The following is a description of a gene set: studied in species Mus musculus Mouse Gene Set: GOCC_ENDOPLASMIC_RETICULUM The irregular network of unit membranes, visible only by electron microscopy, that occurs in the cytoplasm of many eukaryotic cells. The membranes form a complex meshwork of tubular channels, which are often expanded into slitlike cavities called cisternae. The ER takes two forms, rough (or granular), with ribosomes adhering to the outer surface, and smooth (with no ribosomes attached)., and this is the list of marker genes: Lrit3, Cercam, Sec61bl, Sema4f, Cyp3a41a, Nat8f2, Bfar, Mboat1, Elovl2, Slc30a9, Sec24d, Zdhhc4, Rps29, Hsd3b3, G6pc1, Apbb2, Ddn, Shisa5, Znrf4, Cd1d2, Nr3c2, Hrc, Gdi1, Minpp1, Dse, Tsn, Sqstm1, Gabarapl2, Nhlrc1, Icmt, Cyp3a25, Camk2d, Mgat4d, Atp8a1, Keap1, H2-M10.4, Ugt1a9, Ugt1a7c, Ebpl, Ch25h (cholesterol 25-hydroxylase), Apob (apolipoprotein B), Rps3a1, Mlec, Srd5a1, Arxes2, Mpig6b, Or7a40, P3h3, Cyp2a4, Scd4, Dlc1, H2-M10.3, Eef1g, Gabbr1, Prkcd, Vps13c (vacuolar protein sorting 13C), Il12a, Pigg, Ier3ip1, Tmed6, Creb3l3, Golt1b, Cemip, Hspbp1, Rp9, P4ha3, Creb3, Stard3nl, Abhd12b, Gnai3, Bace2, Pkd2l1, Duox2 (dual oxidase 2), Osbpl6, Pcdha2, Tmem86b, Phtf1, Sumf1, Tmtc3, Apoc1, Rnf133, Pigb, Rpl10, Ano9, Ufl1 (UFM1 specific ligase 1), Rnf148, Rpl34-ps1, Or10j5, Edem2, Plpp2, Prkce, F12, Agr2, App, Slc39a7, Mttp, Ryr1, Ldaf1 (lipid droplet assembly factor 1), Tenm1, Jph2, Lama3, Stx16, Fam8a1, Mogat1, Agpat2, Ugt8a (UDP galactosyltransferase 8A), Stau1, Retreg3, 1600014C10Rik (NCBI Gene Id 72244), Frey1, Ddrgk1, Rtn2, Alg13, Myrfl, Mtmr9, Abcb9, Maco1, Rpl27a (NCBI Gene Id 26451), Ubqln4, Glul, Usp25, Stub1, Pld1, Wfs1, Pja2, Selenon, Col6a1, Cyp3a41b, Sumf2, Pdilt, Ctdnep1, Zc3h12a, Atp8b1, Tm4sf20, Cyp39a1, Lemd2, Itpkb, Hap1, Cyp2c37, Tmem67, Esyt3, Mlc1, Dmtn, Arsa, Acat1, Epha5, Duoxa1, Pcdha4, Emc1, Tmt1a, Tpp2, Apex1, Wnt6, Cerkl, Dpy19l1, Tmem30c, Gm5431, Pip4k2b, Cd3e, Rnf185, Nol3, Clcn4, Dolk, Dsc2, Tmem170, Txndc16, Ube2g2, Ythdc2, Get1, Rnf122, Thbs4, Lrp5, Dio1, Soat2, Pofut2, Lpcat3, Vhl, Rheb, Fibin, Arb2a, Alg3, Rab3gap2, Dhrs7c, Lrrc8d (leucine rich repeat containing 8D), Itpr1, Insig1, Tlcd4, Hsd17b2, Cyb561d2, Yipf4, Or2c1, Asph, Derl3, Ndfip2 (NCBI Gene Id 77152), Ubxn4, Ggt1, Poglut3, Ssr2, Saysd1, Hk2, Bscl2, Alg11, Rab10, Utp15, Mal, Cyp2a5, Stim2, Clic1, Atp2a3, Bcl2l1, Lmbr1l, Sdf4, Gpx7, Steep1, Mgst1, Pigv, Dus2 (NCBI Gene Id 66369), Pomk, Parp6, Ormdl3, Ero1b, Arxes1 (adipocyte-related X-chromosome expressed sequence 1), Vcpip1, C2cd2l, Vapb, H2-M11 (histocompatibility 2, M region locus 11), Rce1, Pcsk9, Tor1b, Serpina1b, Apod, Fitm2, Atg9a, Naxd, Hyou1, Mmp27, Kcnq1, Cyp2d9, Tmc8, Tmem100, Ncstn, Por (cytochrome p450 oxidoreductase), Slc39a1, Sacm1l, Atl3, Vti1a, Uvrag (NCBI Gene Id 78610), Pigyl, Lman2, Dhcr7, Tap1, Mmgt1, Acsl4, Tmem33, Pacs2, Awat1, Degs1, Emc8, Mamdc2, Fkbp1b, Rnf26rt, Rdh16f2, Aqp11, BC016579, Alg9, Cyp4a12a, Rnf103, Gramd1b, Dnase1l1, Pgs1, Tmem199, Cdc14a, Aph1b, Rnf180, Oprm1, Nsdhl, Sdr16c5, Ahcyl1, Ptpn1, Tex2, Fmn2, Tmem120a (NCBI Gene Id 215210), Pgap2, Sec22b, Rnf121, Alg14, Alg10b, Tor4a, Sptlc3 (serine palmitoyltransferase, long chain base subunit 3), Or5b21, Tmem147, Pomgnt2, Duox1, Pomp, Ppib, Sel1l2, Marchf2 (NCBI Gene Id 78665), Pomt2, Usp20, Sort1, Notch1, Rab9, Tlcd3b, H2-Q1, Dipk1c, Elavl1, Grina, Tmem109, Vapa, Rdh10, Agpat3, Rnf125, Plcd4, Ubxn1, Kdelr2, Phex, Colgalt2, Cast, Pex3, Ephb1, Zdhhc18, Atg2b, Pdcl2 (NCBI Gene Id 93801), Tapt1, Nat8b-ps, Brsk2, Tram1, Ptdss2, Cpeb4, Becn1, Slc2a4 (NCBI Gene Id 20528), Yipf5, Creb3l2, Syncrip, Rsad2, Cyp26b1 (NCBI Gene Id 232174), Col26a1, Esyt1, Sec61a2, Pdcl3, Marchf1, Grin2b, Tmem86a, Tenm2, Igll1, Pld4, Nat8f7, Nkiras1, Edem3, Rpe65, Pigs, Usp19, Man1b1, Ccdc78, Vpreb3, Emid1, Scn5a, Irgm1, Cybc1, Tcl1, Fam20a, Spcs1, Tmbim4, Srp72 (signal recognition particle 72), Vash1, Atp11c, Ces2a, Cers3, Lrpap1, Prkn, Tmem106c, Ces1a, Pmel (NCBI Gene Id 20431), Cd320, Cert1, Hacd2, Alg6, Ache, Tmem94, H2-Q2, Pyurf, Tmed10, Wnt7a (wingless-type MMTV integration site family, member 7A), H2-M10.6, Osbpl1a, Hsd3b4, Eef1a2, Wnt1, Fads2, BC031181, Creb3l1, Gdpd5, Pigu, Rtn1, Canx, Pkm, Tdrd6, Rps26, Prnp, Vcp (valosin containing protein), Erlin1, Sec63, Slc27a2, Rpl36a, Rcn1, Pdia2, Slc43a1, Cyp2j5 (cytochrome P450, family 2, subfamily j, polypeptide 5), Dpm1, Tbl2 (transducin (beta)-like 2), Hsd3b7, Tmx4, Dhrs9, Loxl2, Cavin1, Trim59, Rnaset2a, Lrrc8b, Napepld, Lgi1, Tmtc4, Wnt7b, Furin (furin, paired basic amino acid cleaving enzyme), Ficd, Lnpk, Sdcbp, Atp1a1 (ATPase, Na+/K+ transporting, alpha 1 polypeptide), Ptgs2, Cyb5rl, Atp13a1, Ugt3a1, Zfyve27, Sec61g, Th, Atp11a, Extl3, Fsd2 (fibronectin type III and SPRY domain containing 2), Tmem129, Flrt1, Alkbh1, Bche, Man1c1, Mtmr12 (NCBI Gene Id 268783), Amfr, Plscr2, Trappc1, Ins1, Sgpp1, Tmem151a, Pnldc1, Alox5ap, Trpm4, Treml4, Samd8, Kcnd2, Cisd2, Rpl10-ps3, Ubac2, Tmem235, Flrt3, Fbxo2, Mgst3, Duoxa2, Sec13, Pex16, Srpx, Pcdha1, Zdhhc19, Faf2, Selenof, Ptp4a1, Cds1, Hsd17b7, Selenot, Lrp6, Ces2c, Gper1 (G protein-coupled estrogen receptor 1), Calr4, H2-M9, Fzd9, Rdh1, Abcg1, Ildr2, Necab3, Cers1, Tmem38a, Fads3 (fatty acid desaturase 3), Alg8, Pigp, Fkbp8, Erap1, Shisa2, Ebp, P3h2, Retreg1, Ptgis, Ahsa1, Ces1h, Dnajb11, Prom1, Pomt1, Derl2, Ghitm, Pde3b, Fkbp1a (NCBI Gene Id 14225), Scfd1, Lrrtm1, Mmp23, Cln5, Lrrk2, Stau2, Abcb6, Xdh, Cyp2c29, Rab32, P2rx6, Aifm3, Ostc, Zdhhc21 (zinc finger, DHHC domain containing 21), Pld6, Hsd17b6, Ldah, Usp17le, Fkrp, Ssr4 (NCBI Gene Id 97594), Cav1, Ndrg4, Serp1, Trappc2, Klhl41, Capn2, Tmem41b (NCBI Gene Id 76341), Rps6, Casp4, Ntf3, Dst, Cyp4f18, Triqk, Panx2, Abca4, Eif2ak3, Zfyve1, Nenf, Cyp26a1, Tm7sf2, Clstn2, Scp2 (NCBI Gene Id 99990), Lclat1, Nrxn1, Extl1, Pdzd8, Mip, Stc2, Yif1b, Smpd4, Tmem247, Tmem30a, Cyp7a1, Rplp0, Gigyf2, Arl6ip1, Saraf, Prss56, Fdft1, Agpat4, H2-M1, Tmem35a, Kcna1, Gpat3, Kdelr1, Tmprss3, Hgfac, Fndc5, Trp53, Dlg4, Stom, Hmox2, Myrf, Cspg5, Nck2, Tecr, Elovl3, Dbndd2, Cyp1a2, Dbi, H13, Aup1, Akap7, Ergic2, Zdhhc14, Kpnb1, Ubxn7, Sult2b1, Acsl1, Pdia3 (NCBI Gene Id 18794), Sptssa, H2-K1, Smim14, Grin1, Art1, Traf2, Cftr, Fkbp14, Pik3r1, Lmf1, Clec2h, Ryr2, Map2k1, Plpp6, Pigz, Pml, Atp13a4, Myo5a, Txndc11, Tmtc1, Atl1, Fgfr3, Alg2, Dnajc18 (DnaJ heat shock protein family (Hsp40) member C18), Tmed5, Sec11a, Piga, Jph3 (NCBI Gene Id 57340), Rpl18, Ganab, Pycard, Nat8f1, Dgat2l6 (NCBI Gene Id 668257), Ms4a4a, Dhrs7b, Serac1, Emc7, Hsd3b8, Mppe1, Uggt2, Cyp2s1, Alg1, Slc18a1, Ywhae, Pkmyt1, Neu4, Casp12, Tlr7, Trappc2l, Tlr9, Usp14, Bcl2l10, Flrt2, Clptm1l, Tfg, Msmo1, Cdnf, Ktn1, Gramd1a, Ugt1a10, Pld3, Slc35b4, Sec16b, Emc3, Bok, Tmem230, Bace1, Uggt1, Acsl6, Acsl5, Parp8, Fkbp10, Glud1, Atp2c2, B3galnt2, Rasgrf2, Nceh1, Asgr2, Bnip3l-ps, Ces1b, Trappc5, Stx17, Chrna3, Cyp2c70, Srp54a (signal recognition particle 54A), Timm50, Dnajc16, Fgf3, Tmem64, Pck1, Atp2a2, Rpl27, Oas1b, Ces1e, Slc27a6, Rab1a, Tram2, Rps28, Cpq, Srprb, Dbh, Get3, Tapbp, Rnf43, Zdhhc12, Drd1, Piezo1, Sh3glb1, Eogt, Tmem14a, Ugt1a2, Aph1a, Dgat1, Zdhhc16, Pafah2, Upk3a, Serpina1e, Ddost (NCBI Gene Id 13200), Cln3, Tmem203, Adam10 (a disintegrin and metallopeptidase domain 10), H2-M2, Bak1, Tmem260, Gjc1, Cnbp, Lpcat2b, Tmcc3, Tafa1, Emc9, Rrbp1, Ptchd3, Hpd, Lrat, Crtap, Lmbrd1, Sel1l, H2-M10.2, Tmem50b, Olfm1, Ugt3a2, Mospd2 (motile sperm domain containing 2), Rpn2, Tmed9, Degs2, Atp10b, Slc17a3, Cdipt, Tmx2, Ei24, Psmf1, Oas1a, Eda, Suco, Tab1, Rpl13, Serpina1a, Eef1b2, Pip4k2c, Srebf2, Ankrd13c, Pdzd2, Minar2, Clec2g, Nrros, Copg2, Cyp4a12b, B3glct, Hsp90b1, Prss50, Pigc, Nos1, Plcb4, Rtp2, H2-Q4, Nat8f3, Cyp19a1, Sec31a, Hsd3b5, Pigh, Serpina1f, Zdhhc1, Hsd3b9, Edn1, Dmpk, Usp17la, Wnt4, Rtn3, Slc33a1 (NCBI Gene Id 99713), Lrrc25, Fbxo6, Slc37a4, Ergic1, Atp11b, Bcap31, Scara3, Ank1, Rps6-ps4, Cyp2c23, Atg14, Irag1 (inositol 1,4,5-triphosphate receptor associated 1), Cyp2b9 (cytochrome P450, family 2, subfamily b, polypeptide 9), Aldh3a2, Gimap8, Man1a2, Nbeal2, Myorg, Herpud1, Pigx, Ghdc, Mapk8ip3, Nbas, Nucb2 (nucleobindin 2), Pgap3, Pdia6, Abca17, Erg28, Mtmr6, Gba2, Lss, Ifi47, Chp1, Ahcyl2, Arsg, Plod2, Dnajb14, Creld2, Rhbdf1, Slc35d3, Cib1, Ces1g (NCBI Gene Id 12623), Trappc3l, Hhatl, Rnf13, Rdh16, Kcnip3, Yipf6, Dnajc1, Sez6l2 (seizure related 6 homolog like 2), Gucy2e, Ces2e, Pcsk1, Cyp7b1, Abhd12, Rpl36al, Arl6ip5, Stx18, Phtf2, Cyp3a44, Pcsk5, Pygm (NCBI Gene Id 19309), Ugt1a8, Rpl6, Atp6ap2, Svip, Poglut2, Selenos, Kcnrg, Sec23b, Cideb, Tusc3, Pigk, Hsd11b1, Diaph2, Rnf41, Htr1b, Hsd3b1, Cyp2b10, Rtp1, Agpat5, Atp7a, Rpl21, Alb, Magea3, Sec62, Akap1, P4ha2, Atg2a, Ambp, Atxn3, Hyal3, Cyp2u1 (NCBI Gene Id 71519), Anp32a, H2-T22, Cd74, Tpst2, Ubxn2b, Pdia4, Fads1, Nos1ap (nitric oxide synthase 1 (neuronal) adaptor protein), Man1a, Wnt3a, Apoo, Car4, Rab21, Grik5, Reep3, Fmo5, Dhcr24, Xbp1, Sptssb, Arhgap32, Slc26a11, Rab3gap1 (RAB3 GTPase activating protein subunit 1), Slc27a1, Crat, Cnpy2, Washc5, Mymx, Uba52rt, Acer3, Otof, Drd4, Esyt2, Agpat1, Pxdn, Tbxas1, Gsg1, Lrrc59, Nck1, Tmem117, Ckap4, Atp2a1, Akap6, Rab5if, Plod1, Has2, Rasd1, Fkbp2, Ltc4s, Rpl24, Cers2, Stim1, Ilvbl, Ofcc1, Tbc1d20, Rab2b, H2-Q7, Ube2j1, Wdfy4, Emc2, Rps23, Hacd4, H2-Q10, Aldob (aldolase B, fructose-bisphosphate), Mrap, Fgfr4, Tmem63c, Zdhhc7, Sec23ip, Faxdc2, Il2rg, Stt3a, Usp17ld, Atp2c1, Rpl13-ps6, Pi4k2b, Mctp1, Clu, Jkamp, Spg11, Ttyh1, Panx3, Alg5, H2-D1, Gulo, Ubxn2a, Mgrn1, Srl, Use1, Aco1, Tmtc2, Rtcb, Tlcd3a, Clstn3, Lbr, Cyp2r1, Gabarap, Ksr1, Thy1, Mmgt2, Dhrs1, Smo, Jmjd8, Zdhhc6, Gask1a, Cgrrf1, Sppl3, Cyp4a10, Ccdc134, Hsd17b3, Lpin2 (NCBI Gene Id 68012), Scap, Plekhf2, Alg12, Mrap2, Lyz2, Rpl34-ps2, Pcsk7, Syvn1, Sc5d, Ugt1a1 (UDP glucuronosyltransferase 1 family, polypeptide A1), Sec16a, Prap1, Pemt, Elovl6, Colgalt1, Anxa7, S100a1, Peds1 (plasmanylethanolamine desaturase 1), Porcn, Extl2, Zdhhc25, Hhat, Atp1a2, Eef1d, Ext1, Creb3l4, Rps27a, Cers4, Cds2, Erlec1, Adpgk, Spcs3, Vmp1, Camk2g, Bnip1, Gh, Plpp3, Grip1, Lsg1, Spast, Tkt (transketolase), Spink5 (serine peptidase inhibitor, Kazal type 5), Zdhhc13, Ext2, Cyp2w1, Scd2, Armc10, Pcyt1b, Ugt1a6b, Tmcc2, Flvcr2, Slc35a2, H2-T10, Cnr2, Slc35b2, Sdf2, Rdh14, Cyp4v3, Tpd52, Dhrs7l, Pde9a, Caml, Rnf128, Slc30a7, Tmed10-ps, Cyb5r1, Htt, Rnf186, Cyp2c54, Mmel1, Marcks, Tmem43, Fmo2, Rdh5, Dnajb2, Spcs2, Txnrd3, Ano5, Bet1, Nat8, Fgd5, Prkca, Rap1gds1 (NCBI Gene Id 229877), Pld2, Ntf5, Ncln, Lrrc8e, Zfand2b, Tmt1b, Derl1, Tmed2, Tm6sf2, P4ha1, Tmem39b, Cyp2c50, Ptpn5, Sgms2, Rnft1 (NCBI Gene Id 76892), Cyp2c39, Ccdc88a, Sppl2a, Cyp46a1, Psen1, Moxd1, Hsd17b13 (hydroxysteroid (17-beta) dehydrogenase 13), Tmt1a2, Ccdc47, Mest, Clec2i, Lacc1, Pigw (NCBI Gene Id 70325), Plpp7, Aph1c, Oprk1, Dnajc3, Ykt6, P3h4, Gdpd3, Uba52, Clec2e, Tlr3, Notch4, Dpagt1, Fzd6, Srpra, Hace1, Gdpd1 (glycerophosphodiester phosphodiesterase domain containing 1), Asb11, Tmem201, Xk, Fxyd3, Cdk5rap3, Tmbim1, Fktn, Gpaa1, Gabarapl1, Sec61b, Rnf19b, Rab14, Elovl5, Unc93b1, Cyb5r4, Pigl, Selenoi, Srebf1, Taar1, Trdn, Lman2l, Aldh3a1, Sppl2c, Nat8f6, Faim2, Syne2, Lctl, Tgtp2, Grin3b, Bnip3, Mrln (myoregulin), Tgfbr3, Bltp2, Apoe, Epm2a, Calu, Eif2b2, Sri, Zmpste24, Trim13, Agl, Rnf145, Dnajc14, Pdia5, Izumo1, Tmem38b, Calr, Atp8b3, Elovl7, Mapk8ip1, Ern1, G6pc3, Creg2, Prcd, Pnpt1, Atl2, Zdhhc3, Tmed4, Atp10a, Ptgfrn, Rps24, Mr1, Syt6, Agtrap, Retreg2, Prxl2b, Ufd1, Fut11, Sts, Rnf170, Hspa5, Rdh19, Trpm1, Cyp2b19, Tram1l1, Pkhd1, Rnf183, Magt1, Ripk2, Smpd2, Nup210, Nt5c3, Fmo3, Lypla1, Sec61a1, B2m, Cyp4a14, Tyro3, Sln, Osbpl2, Flt3, Sgpp2, Gimap3 (NCBI Gene Id 83408), Afg2b, H2-M10.1, Hmgb1, Pitpnm1, Ifit2, Krtcap2, Rhbdd1, Tmed1, Calhm1, Zdhhc20, Frrs1l, Ormdl1, P4htm, Ifitm3, Cherp, Ctsz, Mgat4b, Ptprn2, Mcfd2, Tor3a, Gria2, Atp2b2, Dnajc25 (DnaJ heat shock protein family (Hsp40) member C25), Bsg, Tomt, Osbpl5, Uso1, Tapbpl, Npc1, Hps6 (HPS6, biogenesis of lysosomal organelles complex 2 subunit 3), Dpm2, Sqle, Ugt2b1, Ephx1 (NCBI Gene Id 98277), Tmem8b, Abcc12, Apbb1, Bax, Ins2, Slc35d1, Rdh9, Angel1, Map3k7, Uba52-ps, Lpcat1, Calr3, Zdhhc23, Vkorc1l1, Prkcsh, Cyp4f14, Abca8b, Sulf1, Grin2a, Cyp4x1, Dio2, Trappc4, Tmem208, Poglut1, Arsi, G6pc2, Tab3 (TGF-beta activated kinase 1/MAP3K7 binding protein 3), Tmem97, Mtdh, P4hb, Tpte, Cyp3a13, Atf6, Cnih1, Grn, Cst7, H2-M5, Entpd5, Ihh, Slc30a1, Fbxw7, Dhh, Hsd17b12, Lpin1, Gpsm1 (G-protein signalling modulator 1 (AGS3-like, C. elegans)), Gpat4, Ces1d, Dnajb12, Ssr1, Cldn10, Oca2, Osbp, Srd5a2, Pou2f1, Cpt1c, Gpr85, Lmf2, Wdr83os, Srpk1, Rnf139, Gm12250, Scd1, Agr3, Fbxw15, Vti1b, Srp68, Glrb, Crabp2, Sar1a, Osbp2, Lman1, Abcd4, Cyp2j9, Osbpl8, Emd, Manf, Kdsr, Hmgcr, Tmt1a3, Anks4b, Tspo2, Npc2, Casq1, Ugt1a5, Sec31b, Sec24c, Bcl2, Cacna1s, Erlin2, Reep5, Marchf5, Tunar, Fgb, Vps13a, Gramd4, Osbpl7, Nomo1, Gucy2c, Rdh7, Tespa1, Fga, Nsg1, Cers6, Dcstamp, Emc6, Dlg1, Chi3l1, Slc51a, Ctsw, Hadhb, Vwf, Pla2g2a, Fa2h, Rangrf, Hacd3, Plin1, Cyp2j6, Mzb1, Gbf1, Snx10, Mettl9, Tmx1, Rint1, Cyp4f39, Tmbim6, Rps3 (ribosomal protein S3), Ank3, Eif5a, Mogs, Mogat2, Usp17lb, Akt2, Eif5a2, Otulinl, Cacnb1, Hspa13, Cybb, Cyp1a1, Hsd3b6, Gramd1c, Cttn, Cnih4, Zdhhc2, Inpp5k, Pgrmc2, Marchf8, Ctsf, Cyp3a16, Abca8a, Itpr3, Edem1, Cyp2d11, Zfand2a, Slc22a13, Dpy19l3, Pskh1, Itpr2, Sigmar1, Atp8b2, Slc10a7, Slc35g1, Acsbg1, A1cf, Txndc5, Ptn, Fmn1, Rpl5, Ugt2b37, Gm4841, Sgcd, Srd5a3, Ryr3, Cln6, Gria1, Tmcc1, Tmed11, Ost4, Reep2, Aqp8, Cers5, Ccdc3, S100a7a, Stt3b, Tmed7, Ngf (NCBI Gene Id 18049), Ern2, Fut10, Bnip3l, Mboat7, Cnih2, Sppl2b, Camk2b, Trappc6a, Cyb5r3, Ecpas, Park7, Pigo, Rcn2, Gnrh1, Clec2d, Dnm1l, Soat1, Sec11c, Atp10d, Cyp2c38, Ybx1, Foxred2, Dpm3, Dipk1b, Zdhhc15 (NCBI Gene Id 68086), Mospd1, Vkorc1, Cacna2d1, Rnf149, Pdcd6ip, Cyp2f2, Tor2a, Msrb3, Mydgf, Lynx1, Cidec, Smim6 (NCBI Gene Id 68528), Slc37a3, Serpinh1, Ufsp2, Ces1f, Rnaset2b, Atp6ap1, Fcrlb, Vcam1, Arhgap5 (Rho GTPase activating protein 5), Sgms1, Rasgrp1, Agmo, 9930111J21Rik1, Tgtp1, Gimap1, Sez6 (seizure related gene 6), Tmx3, Ppp1r15a, Chrm3, Dipk1a, Kdelr3, Rbmx2, Ubqln1, Cyp4b1, Erp29, Jagn1, Cd1d1, Cyp2d10, Plaat1, Prl2c2, Clgn, Jph1, Clcc1, Wnt5a, Shisa3, Igtp, Dolpp1, Clstn1, Dnajc10, Erp27, Rho, Zdhhc22, Il12b, Rnf115, Slc1a1, Ubxn10, Cyp2c55 (NCBI Gene Id 72082), Tmem259, Serpina1d, Cept1, Serpina1c (serine (or cysteine) peptidase inhibitor, clade A, member 1C), Thbs1, Eva1a, Rft1, Acsl3, Cyp2a12, Mxra7, Rdh11, Nlrp3, Hmox1, Pgrmc1, Kcng3, Dhrs7, Pcsk4, Rhbdf2, Catsper3, Vtn, Mbtps1, Sptlc2, Preb, Ufm1, Sez6l, Vma21, H2-Q6, Pld5, Slc22a21, Zp2, Scyl3, Pigm, Hpn, Ptgs1, Trappc9, Egfr (epidermal growth factor receptor), Ubiad1, Sulf2, Kdr, Vac14, Elapor1, Rps7, Fndc4, F830016B08Rik, Slc30a5, Tmem50a, Kifap3, Cmah, Pdcd6 (programmed cell death 6), Col4a3, Kcnn2, Trex1, Tmf1, Ugt1a6a, Tmem258, Ermp1, Traf3ip3, Rab18, Mta1, Plaat3, Shh, Plod3, Chil3, Smpd5, Aoc3, Cyp2c40, Retsat, Tmem214, Cd4, Lpgat1, Lin28a, Set, Slc8a3, Pom121, Tmem30b, Upk1a, Jsrp1 (NCBI Gene Id 71912), Mlana, Reep1, Slc37a1 (NCBI Gene Id 224674), Adipoq, Dgat2, Ireb2, Elovl1, Slc39a13, Sar1b, Fitm1, Arcn1 (NCBI Gene Id 213827), Chpt1, Pkd1 (NCBI Gene Id 224620), Scd3, Ikbip, Txndc12, Atg9b, Adamts9, Lyz1, Fads2b, Zdhhc11, Mbtps2, Acer1, Ccr10, Tmem68, Slc27a4, Epm2aip1, Trappc6b, Lrit1, Thada, Umod, Ambra1, Atf6b, Fam20c, Ces3b, Fndc3b, Ero1a, Map2k2, Ahcy, Sting1, Cubn, Slc37a2, Ric3, Cyba, Gorasp2, Disp3, Slc16a11, Copg1, Sv2a, Map3k5, Ehd4, Rtn4r, Ormdl2, Psenen, Ndfip1, Serp2, Rpn1, Ptges, Nox4, Tex264, H2-T3, Osbpl3, Faah, Aimp1, Psmg1, Rtn4, Erp44 (NCBI Gene Id 76299), Golt1a, Sdf2l1, Pigf, Tmem39a, Slc26a6, Cyb5r2, Pla2g4a, Pde2a, Trappc3, Lrp2 (NCBI Gene Id 99378), Gja1, Prdx4, Ube2j2, Emc10, Pitpnb, Grm6, Pigt (phosphatidylinositol glycan anchor biosynthesis, class T), Sec24b, Ugt2b38, Bcap29, Yif1a, H6pd, Mgat4a, Pigq, Ugt2b5, Reep6, Tor1aip2, Ppp1r15b, Sil1, Zdhhc9, Sptlc1, Fkbp7, Rnf144a, Rps8, Gstm7, Nat8f5, Mblac2, Crhbp, Hax1, Magea9, Kcna2, Prl2c3, Pnpla8, Tex261, Slc36a1, Gosr2, Dnase1l3, Klhl14, Pink1, Os9, Kcnk2, Gusb, Fyn, Pkd2, Insig2, Cyp1b1, Stard3 (StAR related lipid transfer domain containing 3), Pla2g4c, Iigp1, Dtnbp1, Slc35b1, Calcrl, Tmem119, Magea5, Proc, Sec22c, Gba1, Pum3, Cyp3a11, Hsd3b2 (NCBI Gene Id 15493), P2ry13, Dnajb9 (NCBI Gene Id 27362), Cwh43 (cell wall biogenesis 43 C-terminal homolog), Ephx3, Fos, Uba1 (NCBI Gene Id 22201), Lpcat2, Stimate, Clec2f, Vegfa, Lars1, Pofut1, Ankle2, Nat8f4, Uchl1, Tmem132a, Nfe2l1, Ftcd, Pi4kb, Hsd17b11, Pcyt1a, Hmgcll1, Sik2, Bdnf, Marchf6, Tpbg, Lpcat4, Ssr3, Mboat4, Sgpl1, Zdhhc24, Ubxn8, Dnaja1, Cyb5a, Aqp5 (NCBI Gene Id 11830), Sec22a, Pign, H2-M10.5, Tmco1, B3gat1, Kcnma1, Tmem178 (NCBI Gene Id 68027), Elovl4, Atp1a3, Slc26a9, Tap2, Wls, Sorl1, Qsox1, Gpr37, Stard4, Magea8, Rpl34, Ccdc115, Pnpla7, Xxylt1, Zfas1, Smim30, Cav3, Tmem238l, Kcnd3, Selenok, Mia3, Ergic3, Mfsd2a, Myoc, Tmed3, Hacd1, Gpam, Tecrl, Cln8, Aga, Reep4 (receptor accessory protein 4), Lrba, Ggcx, Surf4, Parp16, Wnt5b, Gpc2, Mboat2, Panx1, Mesd, Fkbp9, Arv1, Ptdss1, Gm12185, Fmo1, Hsd17b10, Hsd11b2, Jph4, Rrs1, Tmc6, Rnf26, Ccdc88b, Ddx41, Iigp1c, Sirt6, Cyp51, Bltp1, Vrk2, Cant1 (NCBI Gene Id 76025), Abcd1, Col15a1, Strit1, Slc35b3, Pgap1, Ano7 (anoctamin 7), P3h1, Rnf5, Pcsk2 (proprotein convertase subtilisin/kexin type 2), Nus1, Awat2, Cyp17a1, Trappc2b, Ptpn2, Casq2, Hs1bp3, Aadac, Cped1, Dpy19l4, Cmya5, Faf1, Atg4b, Tas2r118, Wnt3, Mia2, Rictor, H2-T23, Psen2, Sphk2, Dhdds, Itga8, Slc9a6 (NCBI Gene Id 236794), Sgk1, Fkbp11, Atp4b, Itga5, Usp17lc, Zw10, Hcrt, Tmem98, Nploc4, Rps21, Fmo4, Cyp21a1, Uba5, Syne3, Slc36a2, Cyp2d26, Emc4 (NCBI Gene Id 68032), Vpreb1a, Slc22a5, Tmem174, Ndufb8, Stbd1, Ptgds, 1810037I17Rik, Pef1, Rcn3, Fate1, Irag2, Slc39a6, Slc27a5, Ces1c, Cyp2e1, Slmap, Card19, Sec23a, Rpl10l, Mapkap1, Cdkal1, Cnpy3, Ltk, Serinc1, Nat8l, Pln, Irgm2, Gramd2a, Rab2a, Ces3a, Sec24a, Rgma, Rpl4, Lrrc8c, Tor1a (NCBI Gene Id 30931), Tgm2, Tmem131l, Selenom, Dad1, Mtor, Resp18, Mgst2, Ticam2, Or8a1, Nptx1, Pnpla6, Cyp8b1, Yipf7, Slc27a3, Cbln3, Lman1l